Given this list of marker genes Neu3, Syt11, Ubqln2, Sh3gl3, Unc119, here is a description of the gene set: Any process that stops, prevents or reduces the frequency, rate or extent of clathrin-mediated endocytosis. Mouse Gene Set: GOBP_NEGATIVE_REGULATION_OF_CLATHRIN_DEPENDENT_ENDOCYTOSIS species: Mus musculus